Given this list of marker genes PTPN6, CD300LF, FER, CD300A, HAVCR1, ENPP3, TSLP (NCBI Gene Id 85480), LYN, CD226, CD84, PTPRE, SPHK2, RABGEF1, NR4A3, MILR1 (NCBI Gene Id 284021), NECTIN2, PLSCR1, CNR2, CRLF2, here is a description of the gene set: Any process that modulates the frequency, rate, or extent of mast cell activation. Human Gene Set: GOBP_REGULATION_OF_MAST_CELL_ACTIVATION species: Homo sapiens